The following is a description of a gene set: studied in species Homo sapiens Human Gene Set: HP_OPEN_MOUTH A facial appearance characterized by a permanently or nearly permanently opened mouth. Open mouth, and this is the list of marker genes: PIGN, RAI1, FAM149B1 (NCBI Gene Id 317662), TBC1D24, SOX11, H3-3A, EIF2S3, INPP5E, SCN4A, PIGL, KIF7, NONO, DGCR8, ADAM22, KCNK9, H4C5, ASXL3, NGLY1, GCSH, ELN, PLXND1, DEAF1, POMT2, CLTC, HRAS, RNU4-2, POLRMT, DGCR2, NEXMIF, PRKAR1A, PDE4D, GRIA3, TUBB4A, AGO2, NKAP (NCBI Gene Id 79576), VPS13B, PIGT, TCF20, PUS7, HNRNPK, ATP6V1B2, TCF4, ZNHIT3, PDZD8, PARS2, MEF2C, ECEL1, GBA1, MEG3, ZEB2, SIN3A, GFM2, SLC35A2, CACNA1I, RAC1, CTCF (CCCTC-binding factor), STRADA, SLC6A8, AHI1, SLC9A6, OGT, CCDC88A, RAP1B, REV3L, AKT1, DGCR6, SOX5, EXTL3, PPP2R1A, KANSL1, PAK3, CSNK2B, DHX30, RTL1, CHAMP1, DST, CRELD1, MTOR, MAGEL2, ATRX, ATN1, TBCK, ZSWIM6, TFE3, DIS3L2, ASH1L, AP1S2, RPS6KA3, SETBP1, DENND5A, NRAS, DLK1, HOXB1, FOXP1, TBX1, MBD5, POGZ, SNRPN, ESS2, ANKLE2, BCAS3, PIGF, KCNH1, MED12, PPP2R5D, MED12L, IQSEC2, MLXIPL, MGAT2, OCRL, TMEM237, PURA, IL1RAPL1, DPYD, RPS23, FLII, NFIX, MED13L, BRAF, UNC80, LAMA2, KCNJ6, CHD8, TET3, CCDC174